Given this list of marker genes MARVELD1, TBC1D15, RAP1B, NDUFC1, SLC30A2, SPATA13, GRPEL1 (GrpE like 1, mitochondrial), WASHC5, MTR, SGPP1, AZIN1, GULP1, SIK2, TMED5, SLC35F1, REXO4, ZFX, SLC16A14, C15orf48, ZSCAN12, SLC5A8, LUC7L3, TNFSF4, ANKRD42, THAP1, CD34, IDE, PSMB10, HSF5, CXCL3, AP1AR, CDH10, AP2M1, IL18R1, PPA2, C8A, RPAP2, SLC7A5, PARVB, STOX1, SEC14L5, SLC66A1, GALNT3, UBE2H, TPTE, RILPL1, RFC1, MINK1, MMUT, CENPH, BNIP2, GRK2, SOD2, URB2, ISOC1, TNNT2, TIMM8A, CKAP2L, EIF2D, MSH4, WLS, JOSD2, MSS51, GALNT16, ELP5, TLR2, BCL2L13, RPF2, IDNK, TMEM132D, POMGNT1, SLC35A2, SUGP1, SLC30A8, TPRKB, IPO8, MED24, GCFC2, LYRM2 (LYR motif containing 2), NEK5, IVNS1ABP, NDUFS7, SPAG5, GPR160, RAD17, TLL1, CALCOCO1, NOC2L, LPAR2, DGKG, FAM43B, MYO15A, PAG1, ACSL3, SCARB1, RSPH6A, CLNK, UNC45A, MLF2, CLDN22, GATAD2A, STK32B, PYCR2, KALRN, FUBP1, PPAT, TENM1, LRRC47, GRK4, MAGEB5, ERICH6, SNX19, INTS5, CLEC5A, THSD4 (NCBI Gene Id 79875), CORO2B, RTN3, UTP20, SMG9, PRKCB, WBP4, SNAP47, IDS, LIN37, PHF6, CNTD1, BCR, PLCG2, UGCG, CMBL, TENT5A, MITF, PDE3B, ABCC6, PIGS, ALOX5 (arachidonate 5-lipoxygenase), ARL10, VNN2, FAM91A1, TEF, BCAT2, OLFM1, MTBP, SPIN1, HPX, HBA2, HSBP1L1, USP1, SLC20A1, SLC39A1, POLR3K, DHFR, NDUFB9, PSMD2, EFHD2, RAB14, POLD1, EID3, DNER, RTCA, ACCSL, NREP, COL26A1, WFDC5, GPD1L, CALB1, PPP1R2P1, ADAMTS20, ZBTB11, MKKS, CTNNA1, SLC9A4, EMC1, MATN1, RBM11, PRPF19 (pre-mRNA processing factor 19), MEMO1, PCBP2, EMX2, BUB3, RPS18, TMTC4, POLA2, TMEM100 (NCBI Gene Id 55273), TRIP13, LAPTM4B, MLLT1 (MLLT1 super elongation complex subunit), KCNK1, SCN3B, TTC23, WDR55, S100A4, SLC22A7, MOCS3, EPB41, ADPRH, DPM1, ARHGEF40, TUBB2A, CLDND1, here is a description of the gene set: Human Gene Set: GSE39820_TGFBETA1_VS_TGFBETA3_IN_IL6_IL23A_TREATED_CD4_TCELL_UP TGF-beta3 produced by developing Th17 cells induces highly pathogenic T cells that are functionally and molecularly distinct from TGF-beta1-induced Th17 cells. The microarray data represent a distinct molecular signature for pathogenic versus non-pathogenic Th17 cells. species: Homo sapiens from publication Lee Y, Awasthi A, Yosef N, Quintana FJ, Xiao S, Peters A, Wu C, Kleinewietfeld M, Kunder S, Hafler DA, Sobel RA, Regev A, Kuchroo VK (PMID 22961052) Genes up-regulated in comparison of CD4 T cells treated with TGFB1 versus those treated with TGFB3 treated with IL6 and IL23A.